The following is a description of a gene set: Catalysis of the hydrolysis of any acid anhydride. Human Gene Set: GOMF_HYDROLASE_ACTIVITY_ACTING_ON_ACID_ANHYDRIDES studied in species Homo sapiens, and this is the list of marker genes: DHX57, RAB12, CDC42, FGD3, MYCBP2, RAB9B, PTGIR, RAB15 (NCBI Gene Id 376267), DNMBP, AGFG1, SYDE1, DDX17, KIAA1755, MYO9B, HSPA7, RAD50, TBC1D30, DNM1L, GNAI2 (G protein subunit alpha i2), TUBB2A, GFM1, ENTPD1, RAB4B, TSR1, TBC1D8B, PRUNE1, MYO9A, GNG8, CCT3, PREX1, ARHGEF10L, DHX35, RGL3, ARHGAP18, RASGRF1, MYO3A, NVL, TBC1D20, SMCHD1, TWNK, RAB8B, DDX49, RGS2, NUDT5, ARL4A, CYTH2, CHD5, RAB37, ARHGAP21, DENND6A, FGD6, RGL4, ARHGAP23, ABCA9, ABCF2, ALS2CL, DOCK2, HSP90AA1, PPA2, TBC1D3H, RGPD4, RASL10A (NCBI Gene Id 10633), ARHGAP10, VPS9D1, RAB40AL, RAB3C, PEX1, DNAJC27, ABR, HRAS, NKIRAS1, RAP1GDS1, CCT5, ADGRB3, C10orf88, CDC42SE1, ATP6V1H, MCM2, KIF21A, DNAH9, SBF2, DOCK1, OLA1, TBC1D24, EEF2, DHX33, PSD2, IFT22, RALBP1, SRGAP3, DDX56, ATP2B4, SH3BP1, NGB, RUNDC3A, RIC8A, ARL8A, MFN1, AKAP13, RASGEF1B, FIGNL1, ITSN2, PSMC3, OBSCN, IFT27, GARNL3, GSPT2, SMC3 (NCBI Gene Id 9126), DDX39B, MTG2 (NCBI Gene Id 339607), SOS2, RPGR, ATP8B1, RABEP1, ARHGAP24, KIF7, KIF18B, DOCK11, NUDT1, RABL2B (NCBI Gene Id 11158), DDX25, PMS2P5, RAB9A, GIT2, RHOA, ABCA2, KIF25, RAP2B, ABCC9, ENPP1, RAB24, RGPD8, ABCC6, WAS, PLEKHG3, HLTF, AGAP6, TBC1D3G, AFG1L, DOCK8, PLPP4, ARL2, RASGEF1C, ARHGAP1, RCBTB2, DOCK9, GDI1, SLC25A42, ARL13B, ARHGAP8, DCTPP1, SYNGAP1, ARF1, BNIP2, ARHGEF19, GTPBP1, LAMTOR3, PLCE1, PLEKHG2, KRAS (KRAS proto-oncogene, GTPase), RAB3D, RAB44, MMAA, TBC1D2B, DDX28, TDRD12, NUGGC, DNAH5, DHX9, DNAH12, BRIP1, RRAS2, CHD8, NUDT4, EPS8L1, ARHGEF12 (NCBI Gene Id 55406), PMS2P3, GNL2, KIFC1, NAIP, DEPTOR, RAB11A, PLCD4 (NCBI Gene Id 84812), ARL9, RABEP2, IPO7, RASAL1, RAB43, CYTH3 (NCBI Gene Id 9265), TBC1D16, RIC1 (NCBI Gene Id 57589), RAB18, PLEKHG6, GBP4 (NCBI Gene Id 115361), CHD2, TSC2 (NCBI Gene Id 7249), TUBB, ECT2, RAB5A, NUDT11, GCH1, PLXNB1, DENND6B, COQ8B, RABGAP1L, KIF5A (kinesin family member 5A), LAMTOR4, DDX51, DNAH11, ATP6V1A, RSF1, RCC2, RFC5 (NCBI Gene Id 5985), CLPB, TBC1D25, GBP3, CPEB2, RFC2, RAPGEF2, DDX20, ADRA2C, DENND2A, SEPTIN2 (NCBI Gene Id 4735), RECQL, LONP1, ADAP1, PELO, TBC1D4, DDX52, DDX31, GET3, RASGRP3, ARFGAP2, ARHGAP11A, NUDT15, ATP5F1B, ABCD1, RAP1BL, CHD6, ABCB7 (NCBI Gene Id 8252), GTPBP10, YTHDC2, NET1, KALRN, TBC1D3C (NCBI Gene Id 414060), RAPGEF6, PSD3 (pleckstrin and Sec7 domain containing 3), RRAGB, DAB2IP, HSPA13, DENND1A, PLEKHG1, GBP7, ABCG5, ARHGEF37, TBC1D22B, ABCB5, DCP2, TUBB2B, ATP4A, RUVBL2, PLCB1, RAB5B, ARHGAP15, ARHGEF17, ARHGAP6, PSD, NUDT7, RAB17, ARAP1, TBC1D15, GTPBP4, RANBP2, TBC1D22A, SRP54, RALGAPB, ATP11C, RGS6, RGPD6, KIF1B, EEFSEC, GNL1 (G protein nucleolar 1 (putative)), ENTPD6, VPS4B, DDX54, SEPTIN5, WDR41, RGL1, MORC2, KIF3A, ARFGAP1, FGD1, ACTB, RASL11B, DENND11, ARRB1, DDX3X (NCBI Gene Id 730543), ARHGEF7, NUCB2, KATNAL1, GIT1, RAB14, AGAP3, ALS2, ARHGEF38, NUDT10, SPAST, ARHGEF1, ARHGEF16, NUDT16, AGFG2, HSPA9, RIN1, NSF, RHOU, NPRL3, ABCA13 (NCBI Gene Id 206568), TUBB8, RAB6C, ABCC3, RALGAPA2, IQSEC3, HFM1, ATL2, AFG2B, ABCC5, TBC1D3F, RND1, CANT1, RHOV, SMAP1, MCM7, NUBP1, ATP2A2, CCT6B, WRN, ATAD3B, GNA14, RAB34, RAB29 (NCBI Gene Id 8934), TBC1D10C (TBC1 domain family member 10C), ABCA8, ERCC2, EFTUD2, ELMO1, ARHGAP44, ATP10D, ATP5F1C, EVI5, GFM2, TBC1D3I, WASL, NCKAP1L, RASGRF2, MORC3, PEX6, NUDT2, ABCB9, NUDT17, CYTH4, MOV10, TUBB4B, GPSM3, NF1, HBS1L, ARHGAP19, CPLANE2, GDPGP1, RAB23, ELMOD3, SMAP2, TBC1D19, ABCA6, MOV10L1, TOR1B, DOCK4, SGSM3, ATP12A, RASAL2, RNF112, GNAQ, EEF1A2, RND2, CHN2, CHML, SH3BP5 (SH3 domain binding protein 5), PMS2P6, LLGL2, CCT2, GNB2, IQSEC1, GNB5, ABCA5, ABCC12, DDX11, REM2, EIF2S3B, ABCC11, THG1L, RALGDS, SEPTIN8, RTKN, ATAD1, RAB25 (RAB25, member RAS oncogene family), ARL6, ARHGAP33, TBCC, SEPTIN10, RAB39B, RAB42, REM1, PMS1, ARHGEF2, GPN3, RGS8, KIF13B, CRACR2A, FBH1, DOCK3, ERAS, KIF12, SMARCAD1, GRIPAP1, TRPM2 (NCBI Gene Id 7226), ARHGAP28, STXBP5, FARP2, KATNA1, EIF2B3, RRAGD, RHOBTB2, TBC1D7, DENND1B, KRIT1, MYH4, PLCG1 (phospholipase C gamma 1), OPA1, CCT6A, TBCK, DEPDC1, ABCF1, DCPS, PMS2, SWAP70, ARHGAP42, MORC4, SRCAP, MX2, KIF20A, LARS1, BCS1L (NCBI Gene Id 7856), EPS8L3, DDX3Y, RASA4, TBC1D3L, AFG3L2, FBXO8, DDX50, RAD54L (RAD54 like), BCAR3, RAB33B, AGAP7P, TBC1D10B, TUBB8B, ARHGAP5, RANBP10, RIMS1, VPS4A, RAB6B, ATP6V1G3, PMS2P1, EIF2B2, GCGR, SESN2, BTAF1, RAB3A, MDN1, SMC4, RHEB, FARP1 (NCBI Gene Id 10160), KIF2A, ARL14, IRGC, DENND2D (DENN domain containing 2D), DHX30, ATP13A3, NLRP3, ABCB8, CHD7, ATP2C1, RAPGEF5, RASA2, ARHGAP27, EIF5B, RERG, PSMC1, GBP1, ARHGDIA, XRCC5, RAD51, HSPA2, HERC1, ABCC1, SEPTIN3, DOCK6, ENPP5, PREX2, RASD1, DOLPP1, ATAD3C, ABCC10, ADRA2A, WRNIP1, LRRK2, GNAO1 (NCBI Gene Id 2775), ATAD3A, KIF18A, RGS16, FGD5, RGS21, DENND2B (NCBI Gene Id 6764), ARHGEF33, DUT, KIF5C, EIF2B4, RALGPS1, MYO1E, DNM1P34, HELB, PLPP1, ARL5C, ATP13A5, ABCG2, DNA2, SEPTIN1, HSP90AB1, MYH3, SLIT2, POLQ, ATP2B2, ENTPD8, ARF4, RAB20, ATP8B4, ARL3, FGD2, TOR3A, ARFGEF1, DXO, PGP, GNA12, DNAH6, CARNS1, TRIM23, KIF2B, ARL4C, RAB7A, RAPGEF1, EEF1B2, SPG7, RFC4, RRAGC, RGS14, ATP2A1, HSP90AB3P, SMC2, NAV1, RHOD (ras homolog family member D), PPA1, ATP1A1, CHD9 (chromodomain helicase DNA binding protein 9), DDX27, DDX6, KIF1A, ARL1, RAC3, USP6NL, GNB3, NGEF, ARHGEF5, PFN2, ARHGAP9, RAB3GAP2, ATL1 (NCBI Gene Id 6681), ATP2B1, HSPA8, CYTH1, NUDT16L1, DNM3, DHX32, HSP90AB4P, DHX8, RAB30, KIF15, MMUT, DCP1B, ARHGEF40, RAD51D, KIF3B, IPO5, TBC1D21 (TBC1 domain family member 21), RABL2A, XRCC6, SRPRA, ASCC3 (activating signal cointegrator 1 complex subunit 3), KIF20B, RAB3B (RAB3B, member RAS oncogene family), PRUNE2, ABCF3, NUDT12, DEPDC1B, RGS12 (NCBI Gene Id 6002), MCM8, ATP6V1G1, GNAT3, SIPA1L1, HSP90AA4P, ARHGAP25, DIS3, PLPP6, ASAP2, GNB1, KIF22, ABCG1, HSPD1, DNAH7, PSMC5, BLM, TRIO, PREB, LAMTOR2, ABCG4, ARHGEF39, CFTR, KIF1C, KIF3C, TNK2, SMC1B, ELMOD2, RAB13, MTG1, RIGI, ENTPD3, GNAZ, GNG3, TUBB6, DDX21, RAB3GAP1 (NCBI Gene Id 338380), PLEKHG5, TCP1, IQGAP2, RASGRP1, RAP2A, KIF23, RGS19, RAB3IL1, GBF1, RAP1A, SMC6, ORC1, TOR1A (torsin family 1 member A), CILP2, FITM1, SIRPA, NUDT13, ATP7A, KIF6, SEPTIN12, DNAJA3, ATP8B2, MADD, MLH1, FAM13B, HSPA6, MCF2L2, CHD4, RASL11A, KIF5B, RAB26, EIF4A1, AGAP4, DRG2, ORC4, ATF7IP, ABCG8, TAP2, THTPA, SEPTIN4 (septin 4), GNG5, NUDT22, RAB40B, ABCB10, RIC8B, FITM2, KIF26A, RIT1, DHX29, TBCD, DIRAS3, HELZ2, RIN2, RFC3, TBC1D3 (TBC1 domain family member 3), DHX38, ARHGAP26, ATP8A2 (ATPase phospholipid transporting 8A2), CHN1, TBC1D17, GPN1, RALA, RAB2A, RAD54L2, SLC38A9, SEC23B, DDX5, DOCK7, ARHGEF9, TBC1D3E, SUPV3L1, IQGAP3, KIF17, GNA13, ENPP4, TUBA1B, KIF16B, SH2D3A, SEPTIN9, SHOC1, SAR1B, DRG1, DOCK5, SH2D3C, CLU, RINL, RAB21, NUDT8 (NCBI Gene Id 50602), GNAT1, RAB5C, TUBB3, RALGAPA1, GNG10, ATP5PO, ATP13A4 (NCBI Gene Id 84239), GUF1, ABCC2, GAPVD1, SMC1A, DIRAS2, TBC1D5, RGS20, ALDH1A1, DYNC1H1, PSMC4, DDX46, RGPD2, ARHGEF26, RAB27A, APTX, FANCM, RNF213 (ring finger protein 213), SIPA1L2, SKIC2, SIPA1L3, ITGB1BP1, EGF, NLRP1, ARHGAP39, DDX10, NUDT9, ARFGAP3, ITSN1, ABCB4, ARHGAP36, DDX42, ABCD3, EIF2B5, NUDT14, HSP90AA2P, RAB35, ABCB1, EIF5, SNRNP200, ELMOD1, RANGAP1, MON1A, DNAH8, DDX55, KATNAL2, ATP1A4, RAPGEF3, FIGNL2, ECT2L, DDX41, IRGM, RHEBL1, SEPTIN11, VAV3 (vav guanine nucleotide exchange factor 3), RGS17, RGS1, DDX53, RECQL4, ATP2B3, CHD1L, OCRL, GBP6, RABL3, CCZ1, MYO18A, RANBP1, RRAS, DENND10, DNM1, AK9 (NCBI Gene Id 401271), IRGQ, ADAP2, RGS5, AFG2A, ABCB6, DEPDC5, DDX24, AK6, RAB33A, KNDC1, LHPP, EIF4A3, ACYP2, DHX36 (NCBI Gene Id 96337), DNAH10, TOR4A, CLPX, RAB40C, SEC23A, ASAP3, DHX37, RHOG, VAV2, DENND5A, DDX39A, EPS8L2 (EPS8 signaling adaptor L2, NCBI Gene Id 64787), RGPD5, MFN2, KIF2C, DDX18, RAB19, ITPA, RHOT2, CCDC88A, RGS18 (NCBI Gene Id 92122), KIF9, ARF6, HTR2B, LLGL1, RABGAP1, PLEKHG4, ATP13A1, TBC1D8, RHOH, NTPCR, LSG1, RHOJ, GEM, EIF4A2, EEF1A1P5, FHIT, HMGCR, CHTF18, ARHGAP40, SH3BP4, RAB31, KIFC2, IFIH1, DNAH2, C9orf72, ATP11A, SOS1, CCT8, RHOF, ARHGEF10, PCP2, NRAS, SMC5 (structural maintenance of chromosomes 5), KIF27, TBC1D10A, DYNC2H1 (dynein cytoplasmic 2 heavy chain 1), RAB27B, RAB6A, GNAT2, TUFM, FRMD7, HSPA14, ATP10A (NCBI Gene Id 57194), RALGPS2, CILP, TBC1D26, LAMTOR1, THY1, ABCA10, AGAP2, SLFN11 (NCBI Gene Id 91607), NUDT4B, RUVBL1, EEF1D, RND3, GBP5, RFC1, RRAGA, DOCK10, GNGT2, FGD4, GNA11, DDX23, HSP90AB2P, ARHGEF18, NLRP10, PLEKHG4B, ATP8A1, GBP2, PLPP5 (NCBI Gene Id 84513), RASD2, VCP, PSD4, RGPD3, RAC2, TBC1D2, RAC1, ATL3, ARHGDIG, ABCA4, SGSM2 (NCBI Gene Id 9905), ATP13A2, GTPBP2, MTIF2, MCM9 (NCBI Gene Id 54844), MYO5A, RAP1B, RGS4, ERCC6L, ARAP3, IQGAP1, ARHGAP31, SEPTIN14, NUDT3, DENND2C, ABCC8, KIF19, BCR, KIF13A, PDE6D, ARHGDIB, MCF2L, MSH2, IQSEC2, RCC1, STARD8, RALB, SH3BP5L, ARHGEF3, RGS9, ATP1A3, NAV3, RTEL1, ACAP3, MYO19 (NCBI Gene Id 80179), TIAM1 (TIAM Rac1 associated GEF 1), ARHGAP4, PSMC2, DHX16, GDI2, NAV2, ARL10, SERGEF, TRIP13, RAB38, DHX15, DDX4, ATP1A2, ARHGAP30, PIF1, RECQL5, DENND4B, TPPP, RAB7B, NUDT6, MCM4, EVI5L, ABCA3, RACGAP1, RGS11, ARF3, CDC42EP2, CHM, OPHN1, TUBB4A, ARHGAP45, DENND4A, MCM6, EEF1A1, TBC1D3K, ARL15, PLEKHG7, AGAP1, RASA1, SEPTIN7, DHX58, NUDT19, DDX12P, ARFRP1, SMARCA5 (SWI/SNF related, matrix associated, actin dependent regulator of chromatin, subfamily a, member 5), TBC1D13, GNAI1, RHOQ, TBC1D3B, RANGRF, DEF6, GMIP, VWA8, HSP90B2P, ADPRM, ARHGAP12, DLC1, LONP2, RAB11B, GPS2 (G protein pathway suppressor 2), GSPT1, ARHGEF15, ATRX, VAV1 (vav guanine nucleotide exchange factor 1), ANKRD27, ARL11, ARHGAP29, KIF21B, DMC1, ACYP1, GPSM1, FIGN, MTSS2, RAB28, PHOSPHO1 (NCBI Gene Id 162466), MX1, GTPBP3, ARHGEF6, HPS4, RAB32, UPF1, RGS7, ERCC3, ARHGAP35, RGS10, HERC2, RHOC, RASL10B, ARFGEF2, RIT2, RAB3IP, RERGL, DQX1, CHD3, ATP9B, DENND1C, RAB1A, ABCA12, RRAD, GRTP1 (growth hormone regulated TBC protein 1), PSMC6, ENPP3, SRGAP2, RABIF, TBC1D9, ARL5A, GNAS, CDC6, BMS1, ABCE1, DDX1, ATP7B, TBC1D12, GIMAP7, DDX59, ACAP2, DDX19A, ALPL, ATAD2, NRP1, FLCN, TBC1D14, HPS1, RHOB, GNA15, MLH3, RAB10, RAP1GAP, TDRD9, DIRAS1 (DIRAS family GTPase 1), PDGFRB, TRAP1, ACIN1, MTREX, RGL2, SPATA13, ARHGAP17, DDX11L8, ATP5F1A, RP2, DCP1A, ASMTL, GNAL, ERRFI1, TIAM2, CHD1, ENTPD4, GARS1, YME1L1, SEC61B, ARL13A, ATP9A, SWSAP1, HSPA1B, EFL1, GPS1, ARHGEF25, RASA3, ARHGAP32, AGAP5 (NCBI Gene Id 729092), TOR2A, SAR1A, MRAS, ARHGEF11, NPRL2, HSP90B1, HSPA5, ATP11B, DENND3 (DENN domain containing 3), CCT4, IGHMBP2, RGP1, ENTPD2, TAP1, RASAL3, FAM13A, EIF2B1, ABCC4, ARL16, CCT7, GNG11, DDX43, RASGRP2, NKIRAS2, RAD51B, HSPA1L, RAB36, ATP8B3, TBC1D3D, ARHGAP20, G3BP1, RAB1C, NUDT18, HSPA1A, JUN, RHOT1, ATP10B, RGS13, ARF5, RASA4B (NCBI Gene Id 100271927), DNAH3, AGAP11, KIF28P, MCF2, MYH8, RIN3, ATP6V1G2, ARL5B, RHOBTB3, RAB40A, IQCA1L, STARD13, STXBP5L, RAPGEFL1, EIF2S3, RAB6D, ARHGAP11B, ARFGEF3, RAB2B, DDX19B, AQR, ERCC6, ENTPD5, SGSM1, ARHGAP22, GPN2, RAP1GAP2, ARL2BP, IDE, ATAD5, LAMTOR5, RNGTT, SRGAP1, RASL12, ABCB11, DNM2, ENTPD7, AGAP9, MCM3, RAB39A, ARAP2, DHX34 (NCBI Gene Id 9704), HACD3, SMPDL3A, ABCD2, ZNG1E, DHX40, TBC1D9B, IQCA1, CCDC88C, RAN, KIF14, SBF1, ARHGEF28, RGPD1, ABCD4, RASGRP4, GNGT1, ARL17B, ARHGEF4, DDX60, ACAP1, RAB8A, HELQ, DENND4C, ATP2C2, MCM5, SIPA1, TBXA2R, RAP2C, RAB4A, INO80, RAB22A, TBC1D1, RGS3, RAB41, DDX60L, NUCB1, ABCA7, GNAI3, GRB2, HSP90AA5P, SYDE2, RASEF, ABCA1 (ATP binding cassette subfamily A member 1), ASAP1, RABGEF1, DDX47, GPSM2, RAB1B, RAPGEF4, ARL8B, P2RY12, RHOBTB1, DENND5B, ATP2A3, ARL4D, TUBB1, ADSS1, RASGEF1A, SEPTIN6, RCC1L, ATAD2B, TAGAP (T cell activation RhoGTPase activating protein), SMCR8